The following is a description of a gene set: Genes up-regulated in neutrophils: LPS versus stimulated by CSF2 and IFNG. Human Gene Set: GSE22103_LPS_VS_GMCSF_AND_IFNG_STIM_NEUTROPHIL_UP from publication Kotz KT, Xiao W, Miller-Graziano C, Qian WJ, Russom A, Warner EA, Moldawer LL, De A, Bankey PE, Petritis BO, Camp DG 2nd, Rosenbach AE, Goverman J, Fagan SP, Brownstein BH, Irimia D, Xu W, Wilhelmy J, Mindrinos MN, Smith RD, Davis RW, Tompkins RG, Toner M, Inflammation and the Host Response to Injury Collaborative Research Program (PMID 20802500) Neutrophils play critical roles in modulating the immune response. However, neutrophils have a short circulating half life, are readily stimulated in vitro, and have low levels of cellular mRNA when compared to other blood leukocyte populations. All of these factors have made it difficult to evaluate neutrophils from clinical populations for molecular and functional studies. Here we present a robust methodology for rapidly isolating neutrophils directly from whole blood and develop ‘on- chip’ processing for mRNA and protein isolation for genomics and proteomics. We validate this device with an ex vivo stimulation experiment and demonstrate the ability of the device to discriminate subtle differences in the genomic and proteomic response of peripheral blood neutrophils to direct and indirect stimulation. Lastly, we implement this tool as part of a near patient blood processing system within a multi-center clinical study of the immune response to severe trauma and burn injury and demonstrate that this technique is easy to use by nurses and technical staff yielding excellent quality and sufficient quantity of mRNA for sensitive genomic readout of the host response to injury studied in species Homo sapiens, and this is the list of marker genes: HYCC2, SRGAP2, ANKRD12, FIG4, PTGS1, PCCA, YAF2, PRPF38A, CHCHD3, NDUFB11, AKR1B1, NDUFAF2, QDPR, MAGED1, MACROH2A1, ZHX1, ARHGAP21, MBTPS2, CLDN15, HYCC1, CTC1, CERS6, COX20, VKORC1, TCP11L2, OGFRL1, NSMCE2, HAUS8, SCAI, CTDSPL2, ZWILCH, POLA2, MCCC1, FUCA2, DIP2C, RDH11, NCAPH2, CENPI, NARF, NDUFS6, PPM1L, TBL2 (transducin beta like 2), GPX1, SDHD, ACOT8 (NCBI Gene Id 10005), TRAPPC9, HIRIP3, NSMCE1, QPCT, BUB1, TMEM60, RAD1 (NCBI Gene Id 5810), PRKAR2A, FBXL15, CGRRF1, ACLY, UTRN, MCEE, HUNK, TSEN34 (tRNA splicing endonuclease subunit 34), DNMT1, NEMP1, SRL, PPP1CA, KIF16B, NUDT15, CEP85, PAM, PFDN2, SIRPA, SARNP, DLL1, SFMBT1, FNTB, MNS1, MRPL42 (NCBI Gene Id 64974), SERF1A, CCDC186, MRPL35, SLC25A14, MARCHF3, DCAF7, PAK1, RUNDC3B, RNF145, MFSD13A, CCPG1, ARHGAP18, SPICE1, CHAF1B, CCDC34, FOXP1, TRMT2B (tRNA methyltransferase 2 homolog B), PRKAR2B, TTC39B, CYLD, CD46, OSBPL9, CELF2, DNAAF10, ARID4A, SLC37A1, CMYA5, CPNE3, RELCH, FIRRM, SLC41A1, EXTL2 (NCBI Gene Id 2135), LMO4, IGIP, ACVR2A, TECPR1, RIPOR2, STMN1, CRYZ, CREB3L2, XPR1, ETV6, C9orf85, SDHC, OTUD1, BBX (BBX high mobility group box domain containing), DIAPH3, GPR146, ELOVL5 (NCBI Gene Id 60481), EZH2, NADK2, GPR155, MINDY2, FGD6, NASP, HPCAL1, ATF2, TSC22D1, CDKN1B, GAS2L3, FAM107B, UBR7, LCORL, DHFR, ABHD17A, METTL23, CAPRIN2, LRP8, WIPF1, NDUFB4, HAUS1, LDHA (lactate dehydrogenase A), ATP5MF, CDC45 (NCBI Gene Id 8319), FBXL17, NRP1, MYH10, ATP6V1A, MCM3, ENTREP3, GNPDA2, LARP4, SIK3, APLP2 (amyloid beta precursor like protein 2), CDK1, SCAMP2, TTYH3, TMEM131L (NCBI Gene Id 23240), TP53INP1, SUV39H1, AKAP12, CLN6, WIPI1, ADAMTS6, GATC, MAN1C1, UBASH3B, GRHPR, TSPAN8, FAM76B, MRPL55 (NCBI Gene Id 128308), PRIMPOL (primase and DNA directed polymerase), ABCD1, MMGT1, JKAMP, VCL, CKS2, PSPH, RTTN, RNF39, COMMD9, ZDHHC15, IRS1, UBE4B, ANKRD28, NOA1, GLTP, PAX6, ACAT1, CFD, ARSB, PPP1R12C, HELB, SAP18